Given this list of marker genes AGA, GLB1, MANBA, NAGA, GLA (galactosidase alpha), FUCA1, here is a description of the gene set: studied in species Homo sapiens Angiokeratomas are hyperkeratotic papules that are characterized histologically by superficial ectatic (i.e., dilated) blood vessels with epidermal proliferation. Clinically, angiokeratoma presents as a small, raised, dark-red spot. Angiokeratoma Human Gene Set: HP_ANGIOKERATOMA